Given this list of marker genes GGT7, PCSK1, GGT6, BDH2, HAGH, DMD, MGST2, BLOC1S6, FURIN, AASDH, SLC1A1, GCLC, NFE2L2, LGALS4, SLC7A11, CHAC2, GCLM, SLC1A2 (NCBI Gene Id 6506), PCSK5, MMP7, GGT3P, GGT5, GSS, GGT1, ELANE, CHAC1, here is a description of the gene set: The chemical reactions and pathways resulting in the formation of peptides, compounds of 2 or more (but usually less than 100) amino acids where the alpha carboxyl group of one is bound to the alpha amino group of another. This may include the translation of a precursor protein and its subsequent processing into a functional peptide. studied in species Homo sapiens Human Gene Set: GOBP_PEPTIDE_BIOSYNTHETIC_PROCESS